Given this list of marker genes SFTPD, MMP2, MCOLN2, MTUS1, THBS1, P2RY12, TRPV4, NUP85, TNFSF18, CCL5, LGALS3, AKIRIN1, CD200, B4GALT1, TAFA4, C5AR1, C3AR1, CSF1R, CSF1, EMILIN1, MAPK1, EDN2, MSTN, CD9, CXCL17, SLAMF1, PTK2B, PTPRJ, CYP19A1, TRIM55, RPL13A, EDNRB, BCR, PTK2, CD200R1 (NCBI Gene Id 131450), RARRES2, CCL2, RTN4, CCR2, CX3CL1, CNN2, DDT, CCL3, MAPK3, CD81, AZU1, TREM2, MIR128-1, CKLF (chemokine like factor), CX3CR1, MIR24-1, MMP28, IL34, MIF, CMKLR1, C5, MDK, SAA1 (serum amyloid A1), STAP1, SLAMF8, MMP14, P2RX4, here is a description of the gene set: species: Homo sapiens Human Gene Set: GOBP_MACROPHAGE_MIGRATION The orderly movement of a macrophage from one site to another.